The following is a description of a gene set: from publication Zhong S, Zhang S, Fan X, Wu Q, Yan L, Dong J, Zhang H, Li L, Sun L, Pan N, Xu X, Tang F, Zhang J, Qiao J, Wang X (PMID 29539641) species: Homo sapiens Human Gene Set: ZHONG_PFC_C2_UNKNOWN_NPC, and this is the list of marker genes: CDKN3, KNSTRN, TPX2, SGO2, CCNB2, AURKB, TUBB6, G2E3, CENPE, ASPM, PRR11, KIF4A, GTSE1, KIF22, RACGAP1, TTK, CDC25B, MIS18BP1, AURKA, CDCA8, CDC20, FAM83D, DEPDC1, CKS2, NUSAP1, CENPF, RANGAP1, TRIM59, AMBN (ameloblastin), ENSG00000187951, MKI67, TUBB4B, CCNB1, NDE1, HJURP, KDM4A (lysine demethylase 4A), CDCA3 (cell division cycle associated 3), PSRC1, SPAG5, NCAPD2, KPNA2, MFAP2, UBE2C, KIF20A, DCXR, TUBA1C (tubulin alpha 1c), ZNF649, CEP70, DNALI1, TACC3, NEIL3, CALB2, NDC80, LDHA, TROAP, CCNA2, SPDL1, REEP4 (receptor accessory protein 4), ARHGAP11A, PLK1, CIT, ITCH, MZT1, NEK2, CDCA2, TOP2A, OIP5, DLGAP5, NDST4, CNOT7, PIF1, KIF2C, PHF19, CKAP2L, ARL6IP1, PTTG1 (NCBI Gene Id 9232)